The following is a description of a gene set: studied in species Mus musculus Mouse Gene Set: GOBP_REGULATION_OF_PROTEIN_KINASE_A_SIGNALING Any process that modulates the rate, frequency, or extent of protein kinase A signaling. PKA signaling is the series of reactions, mediated by the intracellular serine/threonine kinase protein kinase A, which occurs as a result of a single trigger reaction or compound., and this is the list of marker genes: Ramp3, Adrb2, Calcr, Adipoq, Akap6, App (NCBI Gene Id 319425), Nrxn1, Aip, Akap12, Drd4, Fshr, Tcim, Akap7, Adissp, Pja2, Iapp, Mif, Akap5